The following is a description of a gene set: Human Gene Set: GOCC_SAGA_COMPLEX species: Homo sapiens A SAGA-type histone acetyltransferase complex that deubiquitinates H2A and/or H2B. This complex is organized into several functional submodules: a structural core including the activator binding module and consisting of ADA1 or a homolog, members of the SPT and TAF protein families as well as promotor recruitment factor TRRAP/TRA1, a histone acetyltransferase (HAT) module consisting of GCN5/KAT2A or PCAF/KAT2B, ADA2, ADA3/NGG1, and SGF29 or homologues thereof, a histone deubiquitinase (DUB) module consisting of ATXN7/SGF73, ATXN7L3/SGF11, ENY2/SUS1 and USP22/UBP8 or homologues thereof, and in some taxa a splicing module consisting of SF3B3 and SF3B5 or homologues thereof (not in fungi). In budding yeast also contains Spt8 which distinguishes it from SAGA-like (SLIK) complex ., and this is the list of marker genes: SUPT7L, PAAF1, TAF5L, KAT2A, TAF5, TRRAP, SUPT3H, USP22, TADA2B, ENY2, SUPT20HL1, SUPT20H, ATXN7, ATXN7L3, TAF9, SUPT20HL2, TADA1, TADA3, SGF29, TAF6, SF3B5, TAF6L, KAT2B, TAF12, TADA2A, TAF10, SF3B3 (NCBI Gene Id 9661)